Given this list of marker genes HAP1 (NCBI Gene Id 9001), SMARCA2, SMC1A, GABBR2, HDAC8, EIF2B2, HDAC1, SYNGAP1, TBL1XR1, SYNE2, STXBP1, SMARCA1, TBL1X, GNAO1, MECP2, HDAC5 (NCBI Gene Id 23342), TCF4, SCN2A (sodium voltage-gated channel alpha subunit 2), GRIN2B, SATB2, GABRA3, FOXG1, CECR2, CRK, SCN8A (NCBI Gene Id 6334), SMARCA4, GPS2, ACTL6B, GRIN2A, IMPDH2, SRRM3, SHANK3, HTT, SCN1A, CHD4, BRAF, CDKL5, HIVEP2, RHOBTB2, MEF2C, TAF1B, KDM5B, GABRD, XAB2, NCOR1, NCOR2, TRRAP, KCNJ10, here is a description of the gene set: Human Gene Set: WP_RETT_SYNDROME species: Homo sapiens Rett syndrome